The following is a description of a gene set: species: Homo sapiens Biconcave vertebral bodies Exaggerated concavity of the anterior or posterior surface of the vertebral body, i.e., the upper and lower vertebral endplates are hollowed inward. Human Gene Set: HP_BICONCAVE_VERTEBRAL_BODIES, and this is the list of marker genes: COL1A2, ZBTB20, CBS, GNPNAT1, COL1A1, USP8, AIP, IFITM5, NOTCH2, TONSL, NANS, LRP5, MBTPS2, KIF22, NOTCH3, NMNAT1, SERPINF1, TENT5A, COL2A1, FKBP10, FN1, PYCR1, IDUA, ARSK, GORAB, TRAPPC2